The following is a description of a gene set: NOD2 is an intracellular receptor for the bacterial cell wall component muramyl dipeptide (MDP) and variants of NOD2 are associated with chronic inflammatory diseases of barrier organs e.g. Crohn disease, asthma and atopic eczema. It is known that activation of NOD2 induces a variety of inflammatory and antibacterial factors. The exact transcriptomal signatures that define the cellular programs downstream of NOD2 activation and the influence of the Crohn-associated variant L1007fsinsC are yet to be defined. To describe the MDP-induced activation program, we analyzed the transcriptomal reactions of isogenic HEK293 cells expressing NOD2wt or NOD2L1007fsinsC to stimulation with MDP. Importantly, a clear loss-of-function could be observed in the cells carrying the Crohn-associated variant L1007fsinsC, while the NOD2wt cells showed differential regulation of growth factors, chemokines and several antagonists of NF-κB, e.g. TNFAIP3 (A20) and IER3. Genes up-regulated in HEK293 cells: expressing mutant NOD2 versus control. studied in species Homo sapiens Human Gene Set: GSE22611_MUTANT_NOD2_VS_CTRL_TRANSDUCED_HEK293T_CELL_UP from publication Billmann-Born S, Till A, Arlt A, Lipinski S, Sina C, Latiano A, Annese V, Häsler R, Kerick M, Manke T, Seegert D, Hanidu A, Schäfer H, van Heel D, Li J, Schreiber S, Rosenstiel P (PMID 21335489), and this is the list of marker genes: MOSPD3, CCL18, COMMD4, CST7, LPXN, RPL41, CSF3, RHOC, IL6, MAPK3, CPE, PUM3, CPA4, LRP2, JAG1, FBXW12, ETNPPL, WTAP, IL36G, SEMA4D, SUCLA2, P2RX3, LYPLA2P1, GBA3, C2orf68, GSC2, TUBA3C, CXCL2, EIF5A, YWHAH-AS1, VPS33A, NME4, CCDC92, RIC8A, GPD1, RPP38, SLAMF7, IL12B, NELL2, PKD1L1-AS1 (PKD1L1 antisense RNA 1), MGLL, EEF1B2, CHAT, CLIC4, SLC25A38, CHD4, ARFIP1, CD59, MAPK10, RPL10A, OR7C2, TAF5L, NDUFA7, GCLM, ITGB2, IFT20, COLGALT2, RPL23AP32, GALNS, EPB42, IL1B, ADRA2B, HAGH, POU4F3, MAP1LC3C, MAK, TMPRSS5, ETFB, FKBP11, MYCNOS, RPL39, CDC5L, ZFHX2, STAU2, PLD1, SLC43A3, TFRC, STOM, RPS15A, SFMBT1, NKIRAS2, CCL5, RGR, PPOX, SLN, LRRC37A2, RPL23A, SURF2, TUBA1C, SCRIB, CBX4, INE1, REXO4, ICAM1, HIKESHI, ARG1, GCH1 (NCBI Gene Id 93984), ESF1, NFAT5 (nuclear factor of activated T cells 5), LSS, C11orf68, PROP1, ARHGEF17, CRMP1, AUTS2, HTR2B, DUSP3, GABRB2, ANXA5, CS, CHUK, PLA2G6, TBC1D4, DUSP22, ACVR2B, HLX, CDH1, PTCD1, LIMK2, MUC13, GADD45B, SERTAD2, PSMD1, MAP3K8, ABCB1, LCP2, STAT4, THSD4, CCL20, CD22, PLEKHB2, GNE, CSF2, PLPP3, PDE4DIP, PTGS2, TSHB, TNF, MMS19, VRK1, SNRPA, PLCB3, OR10H1, RNF31, TFB2M, RPS2P45, RCAN3, AGTR1, TENM1, ULBP1, RPL10, NPM3, NR5A2, CTNNBL1, DRAP1 (NCBI Gene Id 119810), ABCG4, FUT4, CENPT, PEPD, TNNC1, SAMD4A, RPL7A, CAPN15, ITPR1, UPF3A, HLA-J, P2RX4, B3GNT2, TARBP1, H4C11, ABCC10, MSX2, TUBA1B (tubulin alpha 1b), LRRN3, SRSF9, INSIG1, ELP3, PTH1R, GTF3C4, INHBA (NCBI Gene Id 3624), SLCO1B3, ZBTB16, RWDD2B, HPRT1, SPON1, PLK3, FGF18, DRAM1, AHSG, EIF2AK3, TMEM260, EFNA5, CCN5, FANCI, ERVMER34-1, TYRO3, ST7L